Given this list of marker genes GAB1, FGFR2, FGF9, FGF18, TRIB3, PTPN11, FRS2, FGFR4, PIK3R4, THEM4, FGF17, FGFR3, TLR9, FGF2, PIK3CA, FGF7, PIK3R1, FGF20, FGF19, SHC1, FLT3LG (NCBI Gene Id 2323), FGF22, FGF4, AKT2, FLT3, FGFR1, FGF8, PDPK1, FGF6, FGF23, FGF5, KRAS, SOS1, FGF3, PDE3B, IRS1, IGF1R, IGF1, FGF10, GAB2 (GRB2 associated binding protein 2), PIK3C3, IGF2, FGF1, IRS2, FGF16, NRAS, HRAS, KLB, GRB2, KL, PIK3CB, IRS4, PIK3R2, here is a description of the gene set: After autophosphorylation the type 1 insulin-like growth factor receptor (IGF1R) binds and phosphorylates scaffold proteins, IRS1/2/4 and SHC1, which in turn bind effectors possessing enzymatic activity (recently reviewed in Pavelic et al. 2007, Chitnis et al. 2008, Maki et al. 2010, Parrella et al. 2010, and Siddle et al. 2012). IRS1/2/4 can bind both PI3K (via the p85 subunit of PI3K) and the GRB2:SOS complex. PI3K activates PKB (AKT, AKT1) signaling. GRB:SOS stimulates RAS to exchange GDP for GTP leading to activation of RAF and MAPK. part of: Signaling by Type 1 Insulin-like Growth Factor 1 Receptor (IGF1R) Reactome Pathway: IGF1R signaling cascade species: Homo sapiens